The following is a description of a gene set: Mouse Gene Set: GOBP_TOR_SIGNALING The series of molecular signals mediated by TOR (Target of rapamycin) proteins, members of the phosphoinositide (PI) 3-kinase related kinase (PIKK) family that act as serine/threonine kinases in response to nutrient availability or growth factors. species: Mus musculus, and this is the list of marker genes: Sik3, Rps6ka4, Foxp1, Mapkapk5, C9orf72, Akt3, Xbp1, Ube2n, Itfg2, Ywhaz, Usp32, Ube3a, Eva1a, Nckap1l, Tbc1d7, Rps6, Ctns, Ccl5, Mapkap1, Gba1, Ube2d1, Armh4, Tsc1, Pik3ca, Pkhd1, Sesn1, F7, Mtor, Tnfaip8l1 (NCBI Gene Id 66443), Usp4, Disc1, Slc7a3, Rps6ka1, F3, Epm2a, Reln, Ddit4, Rictor (NCBI Gene Id 78757), Tti1, Wac, Eif4ebp1, Sesn3, Kptn, Gsk3a, Usp7, Icmt, Alg13, Tmem127, Gna12, Fnip1 (NCBI Gene Id 216742), Ep300, Rheb, Syk, Spaar (NCBI Gene Id 71406), Lep, Zmpste24, Pih1d1, Npc1, Rnf167, Prkaa1, Lars1, Nlk, Clec16a, Depdc5, F10, Sirt1, Otud5, Card11, Rps6ka3, Nprl2, Sesn2, Gpr137c, Ccdc88a, Castor2, Rragc, Lipa, Peli1, Fnip2, Mtm1, Atm, Mlst8, Araf, Rps6kb2 (ribosomal protein S6 kinase, polypeptide 2), Pdcd6 (programmed cell death 6), Vhl, Lamtor4, Trem2, Eif4ebp2, Wdr59 (WD repeat domain 59), Gas6, Lamtor1, Shq1 (NCBI Gene Id 72171), Rps6kb1, Srms, Meak7, Ros1, Rraga, Usp9x, Szt2, Ube2w, Gpr137, Stambpl1 (NCBI Gene Id 77550), Hdac3, Stk11, Lamtor3, Dgkq, Sar1a, Larp1, Prex2, Ubr1, Gpr155, Klhl22, Fbxo9, Csnk1a1, Rbx1-ps, Prr5l, Smcr8, Flcn, Atxn3, Otub1, Kics2 (NCBI Gene Id 270802), Prex1, Nprl3, Gata3, Prkacb, Rptor, Seh1l (SEH1-like (S. cerevisiae), Ppdpf, Gsk3b, Slc38a9, Syap1, Sec13, Bmt2, Rps6ka6, Slc7a1, Mfsd8, Prmt1 (NCBI Gene Id 80681), Prr5, Src, Tbk1, Rbx1, Rragb, Fam83d, Wdr24, Lin28a, Rragd, Tiprl, Tsc2, Hoxb3os, Sh3bp4, Rps6ka5, Sar1b, Mat2a, Tbck, Rnf152, Endog, Castor1 (cytosolic arginine sensor for mTORC1 subunit 1), Cryba1, Ywhag, Mios, Lamtor2, Dyrk3, Golph3, Cntnap2, Akt1s1, Prkaa2, Otud7b, Pten, Ogt, Pip4p1, Gpr137b, Hif1a, Prkaca, Kdr, Mapk3, Bmal1, Minar1, Cul3, Lamtor5, Akt1, Pim1, Ubr2, Rps6-ps4, Rhebl1, Deptor, Rps6ka2, Htr6, Gpat3